Given this list of marker genes TBC1D20, LRRC39, ZNF451, RNF144B, TGM2, ID3, ACSL1, PXN, ACLY, VSIG8, TSPAN33, DBF4, SNRPD1, HPGDS, FRMD4A, ACOT13, RRP36, MGST2, DHODH, LCORL, INKA1, SYK, C7orf50, CCS, UCP2, ARL6IP1, TXNDC8, REV3L, ANGPTL4, UVSSA, VPS54, MYO6, IL1A, KMT5C, DRAM2, IQGAP1, NOD1, RAP2C, KRR1, PPIG (NCBI Gene Id 9360), TMCO1, HADHA, PNPO, TMEM106C, HILPDA, PTK2B, C5AR1, ASPA, SLC25A16, ELMO2, SAMD9L, RIMS3, EXT1, HERC3, BRCA1 (NCBI Gene Id 672), METTL22, AFMID, CCNL1, MCTS1, CDC42EP2, UNC119, HINT2, SLCO2B1, TMEM263, TGFBR2, GZF1, CLN3, GSTT2, NOTCH2 (notch receptor 2), TSC22D1 (NCBI Gene Id 8848), CLUH, PLA2G6, LCP2, FABP7, RPUSD4, SYNE2, PRKAB1, LAMTOR2, TLR8, ITGAL, PCBD2, MERTK, STARD5, ECHDC1, FAM53B, SCD, DMXL2, CPT1A, EME1, VAV1, TTC39B, FAM83F, IFT70B, DEPTOR, FPGS, PXK, SMAP2, ZFPL1, SUCLG2, ELL, GCFC2, TLE3, AGFG2, PPP1R7, MYD88 (MYD88 innate immune signal transduction adaptor), MRPL22, ALDH9A1, SNX10 (NCBI Gene Id 29887), FILIP1L, GNGT2, LY75, AQR, HADHB, ELK3, TXNDC15, PSTPIP2, ICAM1, ALDOC, IFFO1, PLTP, SIRPB1, SNHG3, IVNS1ABP, AEBP2, ABHD3, AGPAT5, KLHL9, ACADVL, KLHL17, PCYOX1, TBC1D8, PMVK, DCBLD1, TRIM25, SENP2, CCND2, CASP8, AGPAT4, RAB20, ARF4, UTRN, OTOP1, SCARB2, LRRC27, SLC27A1, ANXA2, PLCB2, RAMP1, SDHAF4, CMC1, MPC1 (mitochondrial pyruvate carrier 1), ZCCHC2, PSEN2, CHPT1, MMD, FAM168A, RGS19, SCOC, CCDC61, GPSM3, SEPHS2, TBC1D9, ABI3, OLR1, IFNGR1, AKR1B1, SOD1, MYO7A, ANGPTL3, STARD4, ETFB, MAN2A1, GMPPA, SLC35E3, STAT5A, PPP2R3C, LNPEP, MBP, HSDL2, VPS13D, S100A8, BIRC3, SLC16A1, PRUNE1, GET1, MRPL18, ARFRP1, PRKCA, PPT2, BUD23, IQSEC1 (IQ motif and Sec7 domain ArfGEF 1), SLC22A3, SCARB1, ITLN1 (intelectin 1), H6PD, TAF1D, ARHGAP30, CORO2B, STAG2, ENGASE, here is a description of the gene set: Genes down-regulated in bone marrow-derived macrophages with IL6 knockout and 45 min of stimulation by: LPS versus IL6 and LPS. Human Gene Set: GSE5589_LPS_VS_LPS_AND_IL6_STIM_IL6_KO_MACROPHAGE_45MIN_DN from publication El Kasmi KC, Holst J, Coffre M, Mielke L, de Pauw A, Lhocine N, Smith AM, Rutschman R, Kaushal D, Shen Y, Suda T, Donnelly RP, Myers MG Jr, Alexander W, Vignali DA, Watowich SS, Ernst M, Hilton DJ, Murray PJ (PMID 17114459) studied in species Homo sapiens IL-10 or IL-6 stimulation of control 129xC57BL/6 murine bone marrow derived macrophages in the presence of LPS. We used microarrays to detail the global programme of gene expression changes in response to IL-6 or IL-10 stimulation in the presence of lipopolysaccharide. BMDMs were isolated from control, IL-6-/-, and IL-10-/- mice on a 129XBL/6 mixed background mice and differentiated in the presence of CSF-1 for 6-7 days. Cells were scraped and plated in 6 well plates at 2x10e6/well. Cells were washed with complete DMEM and rested for 1-2 hr before stimulation with combinations of IL-10 (10 ng/ml), IL-6 (2 ng/ml) or LPS (100 ng/ml) for 45 min or 180 mins. Complete biological replicates were performed.